Given this list of marker genes Oaz1, Ins2, Slc7a11, Atcay, Nr1h4, Park7, Ins1, Cln3, Sirt4, Fh1, Slc7a7, Atp2b4, Apc, Hnf4a, Comt, here is a description of the gene set: Mouse Gene Set: GOBP_REGULATION_OF_AMINO_ACID_METABOLIC_PROCESS studied in species Mus musculus Any process that modulates the frequency, rate or extent of the chemical reactions and pathways involving amino acids.